Given this list of marker genes DYRK1A, PPP2CB, MIR219A1, CLU, MARK2, SORL1 (NCBI Gene Id 6653), APOE, here is a description of the gene set: studied in species Homo sapiens Human Gene Set: GOBP_REGULATION_OF_NEUROFIBRILLARY_TANGLE_ASSEMBLY Any process that modulates the frequency, rate or extent of neurofibrillary tangle assembly.